The following is a description of a gene set: studied in species Mus musculus Mouse Gene Set: MIR_676_3P from publication Chen Y, Wang X (PMID 31504780) Genes predicted to be targets of miRBase v22 microRNA mmu_miR_676_3p in miRDB v6.0 with MirTarget v4 prediction scores > 80 (high confidence targets)., and this is the list of marker genes: Hnrnpdl (NCBI Gene Id 52396), 9130008F23Rik, Acta1, Tmem30a, Dimt1